The following is a description of a gene set: The chemical reactions and pathways involving a reactive oxygen species, any molecules or ions formed by the incomplete one-electron reduction of oxygen. They contribute to the microbicidal activity of phagocytes, regulation of signal transduction and gene expression, and the oxidative damage to biopolymers. Human Gene Set: GOBP_REACTIVE_OXYGEN_SPECIES_METABOLIC_PROCESS studied in species Homo sapiens, and this is the list of marker genes: APOA4, PLCG2, MAPK14, PRKCE, PDGFB, GPX3, ABCD2, ITGB2, IL19, ENSG00000274276, HBA1, PINK1, DUOX1, HBZ, CLCN3, NDUFC2, TSPO, PAGE4, ELAVL1, EDN1, TGFBR2, SOD2, SESN1, SIRT5, SH3PXD2B, NAGLU, ATP5IF1, MIR181A2, NOX5 (NADPH oxidase 5), FOXM1, BST1, MIR675, MB, NOS2, SH3PXD2A, NOXO1, BNIP3, RAB27A, MPV17 (mitochondrial inner membrane protein MPV17, NCBI Gene Id 4358), VDAC1, ADGRB1, NOS3, PRDX5, ABCD1, AKR1C1, INAVA (NCBI Gene Id 91162), TNF, APP (NCBI Gene Id 351), MIR590, CCN6, MT3, NOX3, CRP, NCF1, GPX1, NCF1C, HDAC6, PDGFRB, NFE2L2, SIRT3, ACOX1, LPO, SOD3, PRDX2, MAOB, PREX1, ACE2, F2RL1, NDUFS3, ATP7A, GSTP1, SOD1, MIR27B, AKR1C3, SIRPA, G6PD, GADD45A, PARK7, PDK3, SFTPD, ARG2, CYBB, LCN2, HBQ1, PLA2R1, CRYAB, NQO1, SYK, BCO2 (beta-carotene oxygenase 2), CD36 (NCBI Gene Id 948), DHRS4, PARL, RHOA, SNCA, NCF4, PRG3, TLR6, PON3, STK17A (serine/threonine kinase 17a), PAX2, GRIN1, NCF2, FBLN5, SLC25A33, FPR2, HBA2, RAC2, HBG2, ZC3H12A, PRCP, THBS1, SIRT2, MIR21 (NCBI Gene Id 406991), COQ7, NCF1B, PRDX4, ALOX12 (arachidonate 12-lipoxygenase, 12S type), SHC1, IFI6, CCN1, HBG1, INS, FYN, PIKFYVE, SPHK2, F2, CBS (NCBI Gene Id 875), TAFA4, MYCN, RIPK1, MPO, RAC1, CYGB, NOX1, LIPA, NOX4, ABCB7, CYP1B1, CCN2, MPV17L, DRD5, NDUFS4, UCP2, PID1, CBR1, CCS, FAS, TGFB1, TFAP2A, EIF6, FAM210B, MIR24-1, TXN, MT-ND2, MMP3, P2RX7, ACP5, DUOXA1, ALOX5, IMMP2L, ADCY10, HBM, SESN2, GCH1, PRDX1, DHFRP1, CDKN1A, HVCN1, PPARA, PRKN, TLR4, SLC5A3, BMP7, AGTR1, PLIN5 (NCBI Gene Id 440503), DUOXA2, PDK4, ITGAM, GRB2, LRRK2, ATG5, TYROBP, CLEC7A, SLC18A2 (solute carrier family 18 member A2), ROMO1, SLC1A1 (NCBI Gene Id 6505), HP, IER3, TUSC2 (NCBI Gene Id 11334), BCL2, LETMD1, FOXO3, TP53, CYP1A2, STAT3, PMAIP1, ACOD1, HBB, CFLAR, MAPT, DDIT4, CD177, FOXO1, CAT, PXDN, DCXR, ABCC9, NOXA1, PRDX3, NNT, GNAI2, HBD, CYB5R4, BCR, GBF1, TIGAR, MFSD8, RIPK3, GLS2, EPX, CYBA, NRROS, DUOX2 (dual oxidase 2), HBE1, UCP1, LEP, ARF4, RNF41, PRKCD, RFK, COL6A1, VAV1, ZNF205, BRCA1, BIRC2, PXDNL, CYP1A1, DHFR, PRDX6, AGT, NDUFS6 (NCBI Gene Id 4726), TPO (NCBI Gene Id 7173), HK2, TRAP1